The following is a description of a gene set: studied in species Homo sapiens Peptide hormones. Human Gene Set: MODULE_382, and this is the list of marker genes: VIP, CGA, SST, PPY, GCG, TRH, POMC, STC2, PENK, GIP, NPY, CCK, AGT, STC1, CGB3, CALCA, INHBA, CCL25, IGF2, CHGB, LHB, TSHB, IGF1, PNOC, NTS, INHA, CSH2 (NCBI Gene Id 1443), ADM